Given this list of marker genes HELB, PRIM1, PRIMPOL, PRIM2, POLA2, POLA1, here is a description of the gene set: The synthesis of a short nucleotide polymer using one strand of unwound DNA as a template. The product is usually a RNA molecule between 4-15 nucleotides long that provides a free 3'-OH that can be extended by DNA-directed DNA polymerases. In certain conditions, for example in response to DNA damage, some primases synthesize a DNA primer. Human Gene Set: GOBP_DNA_REPLICATION_SYNTHESIS_OF_PRIMER species: Homo sapiens